The following is a description of a gene set: species: Mus musculus Lysosome Vesicle Biogenesis Mouse Gene Set: REACTOME_LYSOSOME_VESICLE_BIOGENESIS, and this is the list of marker genes: Dnajc6, Ap1s1 (adaptor protein complex AP-1, sigma 1), Bloc1s1, Clta, Ap4e1, Clvs1, Ap1b1, Ap1s2, Hgs, Cltc, Dnm2, Ap1m1, Txndc5, Ap4m1, Cltb, Ap4s1, Arrb1, App, Ap1m2, Gns (NCBI Gene Id 97675), Dnase2a, Ap1s3, Sh3gl2, Vamp8, Ap1g2, Hspa8, Clvs2, Vamp2, Chmp2a, Ap4b1, Ap1g1, M6pr, Ctsz, Arf1